The following is a description of a gene set: Mouse Gene Set: CUI_T_CELL_GD_IL2_RESPONSE_UP studied in species Mus musculus Cytokines mediate cell-cell communication in the immune system and represent important therapeutic targets. A myriad of studies have highlighted their central role in immune function, yet we lack a global view of the cellular responses of each immune cell type to each cytokine. To address this gap, the authors created the Immune Dictionary, a compendium of single-cell transcriptomic profiles of more than 17 immune cell types in response to each of 86 cytokines (>1,400 cytokine-cell type combinations) in mouse lymph nodes in vivo. A cytokine-centric view of the dictionary revealed that most cytokines induce highly cell-type-specific responses. For example, the inflammatory cytokine interleukin-1β induces distinct gene programmes in almost every cell type. A cell-type-centric view of the dictionary identified more than 66 cytokine-driven cellular polarization states across immune cell types, including previously uncharacterized states such as an interleukin-18-induced polyfunctional natural killer cell state. from publication Cui A, Huang T, Li S, Ma A, Pérez JL, Sander C, Keskin DB, Wu CJ, Fraenkel E, Hacohen N (PMID 38057668) Genes positively differentially expressed in cell type: γδ T cell upon treatment with cytokine: IL-2 in mouse lymph nodes in vivo., and this is the list of marker genes: Ran, Snrpd3, Magt1, Dcaf1, Fdps, Dnajc3, Utp20, Eif1ax, Ptma, Hnrnpf, Bcl2, Atp5mc3, Gar1, Smyd2, Ipo7, Bax, Slc29a1, Nampt, Pdia4, Ebna1bp2, Zfp593 (NCBI Gene Id 68040), Cox5a, Syncrip, Tapbpl, Stat3, Bst2, Casp8, Uqcc2, Rars1, Snrpd1, Phgdh (3-phosphoglycerate dehydrogenase), Aprt, Npm3, Gnl3, Nop10, Mdfic, Degs1, Slc25a5, Eif1a, Smyd5, Samhd1, Hnrnpa1, Srsf9, Mydgf, Ptpn13, Calr, Coro2a, Cyba, Rbm3, Txn1, Jpt1, Mat2a, F2r, Gbp8, Mrto4, Timm10, Mrpl23, Isg20, Znrd2 (NCBI Gene Id 66232), Rexo2, Smarcc1, Arhgdia, Lat, Flt3l, Apex1, Rtp4, Ndufb7, Hyou1, Parp14, Morf4l2, Wdr43 (WD repeat domain 43), Mrps18b, Pcbp1, Psmb3, Tuba1b, Parp9, Manf, Fkbp2, Tubb4b, Il2rb, Bbip1, Mthfd1l, Pdia3, Srsf7, Hspd1, Kdelr2, Cs, Dnajb11, Hspa9, Banf1, Sp110, Dtx3l, Wnk1, Ubl4a, Cfl1, Il12rb1, Tapbp, Snrpc, Uqcc4, Atp5mc1 (ATP synthase membrane subunit c locus 1), Psmb4, Mettl1 (methyltransferase 1, tRNA methylguanosine), Npm1, Ssr4, Ppia, Cdk6, Tap1, Cd82, Nme1, Fbl, Trappc4, Mphosph10, Eif6, Serpina3g, Slamf7, Notch1, Atp2a2 (NCBI Gene Id 319250), Zbp1, Ccnd2, Tubb5, Set, Cox6a1 (cytochrome c oxidase subunit 6A1), Hprt1, Fabp5, Eif3c, Psmb9, Pus7, Igfbp4, Hspa5, Nol9, Cct5, Psma2, Ehd1, Mak16, St13, Mrpl21, Hnrnpu, Smg7, Uba1, Ddx21, Tmed5, Ly6e, Erap1, Mars1, Gbp6, Psma5, Flna, Psma7, Psme3, Pomp, Sec61a1, Sec61b, Slc35a4, Lsm4, Snu13, Wars1, Socs1, Pdia6, Srp9, Ddb1, Gbp2, Cxcl10, Trafd1, Fasn, Nop58, Naa20, Sdf2l1, Psmb10, Adar (NCBI Gene Id 99861), Rmi2, Atp1a1, Atic, Eif5a, Psmb8 (NCBI Gene Id 16913), Irf8, Grwd1, Srsf6, Kars1, Actr3 (NCBI Gene Id 74117), Gbp4, Ltv1, Tnpo3, Atm, Psme1, Mdn1, Cdc42se1, Dynll1, Nhp2, Sec13, Tpm4, Tpr, Zfp281, Wdr83os, Polr2h, Entr1, Nap1l1, Nars1, Mrpl12, Hnrnpa2b1, Rpn1, Bzw1, Hspe1, Hsp90b1, Ndufb4, Psme2, Rrs1, Cycs, Ipo5, Anp32b, Coro1a, Ranbp1, Cysltr1, Hdlbp, Iars1 (NCBI Gene Id 70306), Ldha, Tmbim6, Hsp90ab1, Ssb, Nolc1, Psmb5, Cdc42, Nlrc5, Serbp1, Pa2g4, Larp1, Gspt1, Ppa1, Ltb4r1, Tnfaip8, Rcc2, Tcp1, Caprin1, Ostc, Tsr1, Creld2, Hspa8, Cct8, Tpm3, Ndufb6, Hsp90aa1, Umps, Mthfd2, Uqcrq, Eef1g, Nifk, Tgtp1, Dock10, Eif3b, Atp5f1d, Ndufaf8, Canx, Gbp9, Tomm70a, Txn2, Pmepa1, Cetn3, Pik3cd, Eif2ak2, Fubp1, Calm1 (NCBI Gene Id 12313), Rsl24d1, Ppp1r14b, Ciao2a, Prmt3, Eno1, Nsun2, Xaf1, Eif3a, Cmtm6, Trim30a, P4hb, Impdh2, Shmt2, Khdrbs1, Comtd1, Spcs1, Cish, Cltc, Bysl, Eif4a1, Psmd2, Tex2, Mif, H2-T23, Gzmb, Ndufaf4, Mybbp1a, Snrpf, Lta, Irgm1, Srsf3, Stat1, Ly6a, Cd274, Stip1, Thap12, Hdgf, Exosc5, Dkc1, Smarca4, Rrp15, Dnaja2, Tars1, Prmt1, Ddx39a, Clic4, Nop56, Ncl, Irgm2, Mrps28, Gart, Parp10, Fgl2, Iigp1, Xbp1, Psma4, Hnrnpa3, Snrpd2, Rnf213, Spcs2, Utp15, Sumo2, Wdr77, Hspbp1 (HSPA (heat shock 70kDa) binding protein, cytoplasmic cochaperone 1), Prpf31, B2m, Timm9, Gbp7, Ilrun, Prdx1, Irf1, Rasa2, Ybx3, Kpnb1, Mthfd1, Ybx1, Tap2, Eif5b, Lcp1, Cct3, Lsm6, Sar1a, Eif4g1 (eukaryotic translation initiation factor 4, gamma 1), Dtx1, Il2ra, Fkbp1a, Actg1, Myd88, C1qbp, Furin, Ifi47, Pfn1, Alyref, Hspa4, Mrpl20, Mrps12, Rrp9, Srsf2, Acsl5, Tmem147 (transmembrane protein 147), Eif2s2, Txnrd1, Akt1, Igtp, Pgk1, Hbegf, Heatr1, Tomm5, Rad23b, Lgals3bp, G3bp1, Alkbh1, Eef1e1, Hnrnpd, Eif2s1 (eukaryotic translation initiation factor 2, subunit 1 alpha), Taf10, Cacybp, Srm, Tuba4a, Tma16, Llph, Timm8a1, Aatf, Hnrnpab, Acot7, Ppp1r16b, Isg15, Msn